The following is a description of a gene set: species: Homo sapiens Human Gene Set: MIR6828_3P Genes predicted to be targets of miRBase v22 microRNA hsa-miR-6828-3p in miRDB v6.0 with MirTarget v4 prediction scores > 80 (high confidence targets). from publication Chen Y, Wang X (PMID 31504780), and this is the list of marker genes: SLC35F2, EGFR, PEX3, DKK2, EIF4E2, ADNP, ABL2, PACSIN2, TRIM71, DDX18, UGT2B17, YBEY, GREM2, FAM204A, RUNX2, GXYLT1, ZZEF1, TNS2, ARMH4, POGLUT1, UBE2N, COQ10B, RAB30, CNOT8, CLDN8, KDELR3, MBP, TMPRSS15, SH3RF3, FBXO9, TBL1XR1, STAG2, SLC36A4, ATRN, S100A10, PAAF1, OSTC, SEPTIN9, IL18RAP, USP4, SERTAD2, IRS1, SSPN, AAK1, AJAP1, ARL14EP, CSNK2A2, SIRPB1, EPHB1, ZNF710, CHRD, MIS12, HIF1A, CNR1, SH3D19, ARMCX4, AMD1 (NCBI Gene Id 262), FSTL5, RBM12, SLAIN2, MTF1, SSC5D, MAN2A2, RPS6KA1, NFIB, HSPA9, BCLAF1, YES1, MTOR, FBXO22, WNT3, ZFP64, TUT4, GUCY1A2, OSBPL6, PTCH1, LSM12, PRKRIP1, THSD7A, PIGA, SET, BRD1, PHACTR2, UBR3 (NCBI Gene Id 130507), NAA15, CEMP1, UGT3A1, ZNF518B, PRMT3, RMND5A, PPP4R4, JARID2, TRMT1L, GPATCH2, KPNA6, ARAP2, KBTBD2 (NCBI Gene Id 25948), SLC5A3, CNST, KIF13A, MLH3 (mutL homolog 3), JTB, TPBG, FAM83A, IPO9, CLDN18, CCPG1 (cell cycle progression 1), MAPK8, FMN1, SERTAD4, PDS5A, THRAP3, FHL1, PPM1B, PFKP, TRIM23 (tripartite motif containing 23)